Given this list of marker genes Ppme1, Pde8b, Elk1, Golga7b, Prr14l, Apmap, Atxn1l, Ace2, Peli1, Gatad2b, Osbpl7, Trp53inp2, Nampt, C1qtnf3, Foxn1, Ilk, Shisa7, Fam221a (family with sequence similarity 221, member A), Map4k1, Clic5, Ccdc3, Atp6v0c, Dagla, Slc17a2, Sp1, Arid4a, Ulk2, Bbln, Alx4, Fem1c, Acadm, Asb15, Zfp456, Dcaf12, Acbd6, Stx5a, Entrep2, Trappc2, Prl7b1, Dnajb4, Tspan18, Mcm7, Slc8a1, Spire1, Htra3, Cyb561a3 (NCBI Gene Id 76431), Sbno1 (NCBI Gene Id 272223), Tlk2, Atp1b4, Ankrd63, Frmpd3, Ccdc177, Dpf2, Ptgir, Capn12, Cenpq, Rab33b, Rnf39, Endod1, Mtarc1, Slc35a2, Sesn2, Ednrb, Fam117a, Bcat1, Fev, Zfp408, Abcg4, Rprd1b, Nfia, Pde6d, Krtap13 (NCBI Gene Id 16699), Ptgdr, Tshz3, Syce2, Aqp4, Krt31, Cgn, Cish, Dpy19l2, Cramp1, Ldlr, Hmgb2, here is a description of the gene set: Genes predicted to be targets of miRBase v22 microRNA mmu_miR_6958_5p in miRDB v6.0 with MirTarget v4 prediction scores > 80 (high confidence targets). species: Mus musculus Mouse Gene Set: MIR_6958_5P from publication Chen Y, Wang X (PMID 31504780)